Given this list of marker genes FGF5, GRB2, FGF20, PPP2R1A, FGF4, RPS27A, FRS2, MKNK1, FGF9, MAPK3, FGF23, FGF6, FGF8, SRC, FGF10, PPP2CA, FGF3, UBC, MAPK1, UBB, PTPN11, SPRY2, UBA52, FGF1, FGF17, BRAF, FGF22, FGF2, ANOS1, PPP2CB, FGFR1, KL, CBL, here is a description of the gene set: Once activated, the FGFR signaling pathway is regulated by numerous negative feedback mechanisms. These include downregulation of receptors through CBL-mediated ubiquitination and endocytosis, ERK-mediated inhibition of FRS2-tyrosine phosphorylation and the attenuation of ERK signaling through the action of dual-specificity phosphatases, IL17RD/SEF, Sprouty and Spred proteins. A number of these inhibitors are themselves transcriptional targets of the activated FGFR pathway. studied in species Homo sapiens Reactome Pathway: Negative regulation of FGFR1 signaling part of: Signaling by FGFR1